Given this list of marker genes SAP18, UPF3B, MFAP1, ZCRB1, NXF1, DNAJC8, YJU2, NUP188, THOC7, PPIL2 (peptidylprolyl isomerase like 2), PRPF6, RBM8A, PPWD1 (NCBI Gene Id 23398), NUP88, FUS, CWC15, SNRPA1, PRCC, NUP42, EIF4A3, CPSF4, RBM10 (RNA binding motif protein 10), RBM42, LSM5, LSM6, ALYREF, FYTTD1, MAGOH, POLR2G, SF3A3, SYF2, PPIL1, CPSF6, ISY1, AAAS, SNRPF, SNU13 (small nuclear ribonucleoprotein 13), HNRNPH2, GPATCH1, NXF2, CPSF1, PNN, TCERG1, SF3B2 (splicing factor 3b subunit 2), DHX8, DDX5, HNRNPM, ZMAT2 (NCBI Gene Id 153527), CPSF3, POLR2E, NUP50, NKAP, WDR70, SNRNP27, UBL5, PCF11, USP39, CWC27, HNRNPD, PPIH, NUP98, PRPF8, DHX35, SRSF12, SLBP, SNRNP200, SNRNP25, RBM7, POLR2B, EFTUD2, CSTF1, U2AF1L4, NDC1, NUP210, SRSF3, POLR2J, NUP85, HNRNPA3, MAGOHB, SF3B4, WBP4, SF3A1, NUP133, SRSF9, RBM5, PRPF40A, THOC6, NUP54, SRRM2, MTREX, BUD31, HNRNPA1, CWC22, PUF60, CWF19L2, POLR2H, SNRNP40, SDE2, PRPF31, RANBP2, CACTIN, CDC40, PPIL4, RBMX2, SNRPD3, PAPOLA, SMU1, SRRT, POLR2D, NCBP2, SF3B5, SRSF1, RAE1, PCBP2, SF3B1, SNRPE, DHX15, NUP153, NUP160, THOC3, CLP1, RNF113A, LSM3 (LSM3 homolog, U6 small nuclear RNA and mRNA degradation associated), HNRNPL, RNPS1, DDX39B, PRPF3, RBM25, NUP43, RBMX, ZRSR2, LUZP4, PRPF38A, SEC13, WDR33, SNRPN, GTF2F2, PRPF4, PPIG, DHX16, CDC5L, FAM32A, NUP37, DDX41, POM121C, HNRNPR, DDX23, NXF2B, RNPC3 (RNA binding region (RNP1, RRM) containing 3), RBM39, TFIP11, SNW1, SNRPB, AQR, PPIE, SUGP1, PQBP1, CSTF3, CTNNBL1, CPSF7, PTBP1, CRNKL1, NXT1, CHERP (NCBI Gene Id 10523), LSM2, SNRNP70, HTATSF1, SF3B3, NUP107, SNRNP48, ZC3H11A, POLR2C, U2AF2, U2SURP, PRKRIP1, SRSF7 (NCBI Gene Id 87459), SF3B6, PHF5A, POLDIP3, SRSF8 (serine and arginine rich splicing factor 8), SRSF4, SNRNP35, POLR2L, SEH1L, LSM7, SARNP, SLU7, GCFC2, WTAP, CCDC12, PDCD7, DHX38 (NCBI Gene Id 9785), SART1, POLR2F, CCAR1, HNRNPA2B1, HNRNPK, CHTOP, CSTF2, BCAS2, SRSF11, CWC25, SRRM1, SRSF10, YBX1 (NCBI Gene Id 7806), DHX9, NUP62, SNRPG, NUDT21, NUP93, TRA2B, METTL3, HNRNPU (heterogeneous nuclear ribonucleoprotein U), GLE1, THOC1, POLR2I, PRP4K, PABPN1, THOC5, THOC2, NUP214, C9orf78, POLR2K, HNRNPC, NUP155, TXNL4A, SRSF2, NUP58, SMNDC1, DDX42, HSPA8, LUC7L3, LSM8, SF1, NUP35, SNIP1, FIP1L1, SF3A2, POM121, PCBP1, PRPF19, NUP205, IK, U2AF1 (U2 small nuclear RNA auxiliary factor 1), BUD13, SNRPC, SNRPB2, LSM4, ZNF830, WBP11, SNRPD1, HNRNPF, PPIL3, XAB2, PLRG1, CASC3, ZMAT5, CSTF2T, HNRNPH1, PRPF18, ACIN1, NSRP1, METTL14, LENG1, SRSF5, EIF4E, GTF2F1, TPR, SRSF6, STEEP1, NCBP1, PPP1R8, CPSF2, SNRPD2, RBM22, SYMPK, POLR2A, DDX39A, DDX46, GPKOW, RBM17 (RNA binding motif protein 17), FAM50A, SNRPA, here is a description of the gene set: species: Homo sapiens Processing of Capped Intron-Containing Pre-mRNA Human Gene Set: REACTOME_PROCESSING_OF_CAPPED_INTRON_CONTAINING_PRE_MRNA